The following is a description of a gene set: Any process that modulates the frequency, rate or extent of a digestive system process, a physical, chemical, or biochemical process carried out by living organisms to break down ingested nutrients into components that may be easily absorbed and directed into metabolism. Human Gene Set: GOBP_REGULATION_OF_DIGESTIVE_SYSTEM_PROCESS species: Homo sapiens, and this is the list of marker genes: TIFAB, PRAP1, ENPP7 (ectonucleotide pyrophosphatase/phosphodiesterase 7), TYMP, NR1H3, CLDN15, CYP8B1, SCT, KCNQ1, ABCG8, GHRL (ghrelin and obestatin prepropeptide), APOA4, WNK1, CRH, PTGER3, TFF2, ABCB1, WNK4, NPSR1, NEGR1, NEUROD1, APOA1, NEUROG1, HAMP, SLC22A5, AQP1, APOA2, WNK3 (WNK lysine deficient protein kinase 3), NMU, PPP3CA, GHSR, OXT, OPRK1, HIP1R, FGF10, ABCG5, STK39 (NCBI Gene Id 27347), LPCAT3 (NCBI Gene Id 10162), SGK1, EPB41, CLDN2, NR1H2, LEP, DCANP1